Given this list of marker genes CHRNB2, CHRM4, CHRNB3, OPRM1, CHRNA3, HRH4, LYNX1, CHRM2, CHRNA4, GNAI2, GRXCR1, ACHE, CHRM5, LY6H, CHRM1, CHRNA2, SLURP2, LYPD1, PSCA, EDNRA, LY6E, ATP2B4, LY6S, CHRNG, RGS10, AGRN (agrin), CHRND, GNA11, GNAQ, CHRNA5, CHRM3, CHRNB1, CHRNA1, CHRNA7, PRKCB, CHRNE, LARGE1, TSPO, ROCK2, CHRNB4, ITPR1, CHRNA6, BLOC1S6 (NCBI Gene Id 26258), PLCB1, CRKL, LY6G6D, GRK2, HRH3 (histamine receptor H3), GNA15, GNB1, RGS8, CDK5R1, here is a description of the gene set: Any process that results in a change in state or activity of a cell or an organism (in terms of movement, secretion, enzyme production, gene expression, etc.) as a result of an acetylcholine stimulus. Human Gene Set: GOBP_RESPONSE_TO_ACETYLCHOLINE species: Homo sapiens